Given this list of marker genes Msn, Icam1, Selenon, Rock1, Ezr, here is a description of the gene set: Mouse Gene Set: GOBP_MEMBRANE_TO_MEMBRANE_DOCKING species: Mus musculus The initial attachment of a membrane to a target membrane, mediated by proteins protruding from the two membranes. Docking requires only that the membranes come close enough for the proteins to interact and adhere.